The following is a description of a gene set: from publication Chen Y, Wang X (PMID 31504780) Genes predicted to be targets of miRBase v22 microRNA hsa-miR-148a-5p in miRDB v6.0 with MirTarget v4 prediction scores > 80 (high confidence targets). species: Homo sapiens Human Gene Set: MIR148A_5P, and this is the list of marker genes: SYCP3, GJB6, RAB8B, ITGA8, PSTK, REEP1, HSPA5, SLC27A6, NT5E, LPCAT2, RBBP6, IQCK, ZFP42, TOMM20, RO60, CDKL2, SLC11A2, SEPTIN10, PPP2R2A, TRIM6-TRIM34, IFT70B, UBR3, KIF27, CACNA1D, RBMXL1, KIF3B, COL10A1, GHITM, SYNCRIP, ABRACL, PTCRA (NCBI Gene Id 89959), TMEM212, H2BC5, THUMPD3, NCAPG, IPO7, CACUL1, SLC7A7, ZNG1C, NAV1, CSNK1A1, SV2A, FAM13B, C6orf62, BSDC1, RBMX, KDM6A, FAM117B, AKAP5, FLT1, DACH1, AMOTL1, PRR27, PDE6C, NIN, ZNF655, SLIT3, EFCAB7, FAM169A, SPOCK3, OIP5, GADL1, AGL, MYO5C, GAS2L3, ZCCHC10, RORA, ICE1, POU4F1, SESTD1, KIFC3, ZNF117, KIF13A, COL5A2, STIL, PCM1, GSR, SGO1, CLCC1, REL, LSM14A (NCBI Gene Id 91161), PIGC, TPP1, BCLAF3, TRAM1L1, SIX4, PAK2, RNF38, MARCKS, OAS1, G3BP2, INA, YIPF5, DCAF4, KMT5B, PHTF2, MICU2, ZWILCH, FANCD2 (NCBI Gene Id 2177), SRI, COBLL1, FLRT3, ZNF214, CFAP298, SYAP1, CLK4, RTKN2, ERFE, SACM1L (SAC1 like phosphatidylinositide phosphatase), POU2F1, C3orf38, PCSK6, CFAP52, NUP50, PPP4R3B, TRIM34